The following is a description of a gene set: Human Gene Set: HP_HYDROXYPROLINEMIA Hydroxyprolinemia species: Homo sapiens An increased concentration of hydroxyproline in the blood., and this is the list of marker genes: SLC36A2, TNFRSF11B, SLC6A20, SLC6A18, SLC6A19